Given this list of marker genes Rgcc, Myo1c, Mcub, Rapgef4, Aopep, Cnga1, Tnfrsf9, Dapl1, Nrp1, Swap70, Mxd1, Mbnl3, St3gal6, Gpr15, Ston1, Tmie, Il2rb, Gadd45b, Il1r2, Atp8b4, Foxp3, Cd79b, Adh1, Sh3bgrl2, Epas1, Map3k8, Plagl1, Stx11, Sema4a, Slc22a15, Neb, Il2ra, Capg, Soat1, Tnfrsf1b, Acsbg1, Ctla4, Cd81, Tanc1, 2900026A02Rik, Ggt5, Nfil3, Lclat1, Bach2, Itgae, Itih5, Rflnb, Ikzf2, Fah, Il1rl1, Rilpl2, Gsto1, Enc1, Penk, Cd83 (CD83 antigen), Tnfrsf18, Chd7, Pdk1, Frmd4b, Arhgap29, Nol4l, Ppm1l, Afp, Anxa4 (NCBI Gene Id 269772), Als2cl, Hopx, Pmaip1, Prkar1b, Vav2, Pxylp1, Apol9b, Alcam, Gpr83, Ramp3, Osbpl3, Il1rl2, Themis, Gpld1, Etfbkmt, Gbp4, Prc1, Tnfrsf4, Sema4f, Niban1, Mmd, Hspa1b, Lypd6b, Cttn, Twsg1, Myo10, Tiam1, Capn3, Pim1, Fasl, Gprc5b, Slc16a5, Ncf1, Syt11, Ttc7b, Rragd, Cdkn2c, A630001O12Rik, here is a description of the gene set: Regulatory CD4+ T cells (Tr cells), the development of which is critically dependent on X-linked transcription factor Foxp3 (forkhead box P3), prevent self-destructive immune responses. Despite its important role, molecular and functional features conferred by Foxp3 to Tr precursor cells remain unknown. It has been suggested that Foxp3 expression is required for both survival of Tr precursors as well as their inability to produce interleukin (IL)-2 and independently proliferate after T-cell-receptor engagement, raising the possibility that such 'anergy' and Tr suppressive capacity are intimately linked. Here we show, by dissociating Foxp3-dependent features from those induced by the signals preceding and promoting its expression in mice, that the latter signals include several functional and transcriptional hallmarks of Tr cells. Although its function is required for Tr cell suppressor activity, Foxp3 to a large extent amplifies and fixes pre-established molecular features of Tr cells, including anergy and dependence on paracrine IL-2. Furthermore, Foxp3 solidifies Tr cell lineage stability through modification of cell surface and signalling molecules, resulting in adaptation to the signals required to induce and maintain Tr cells. This adaptation includes Foxp3-dependent repression of cyclic nucleotide phosphodiesterase 3B, affecting genes responsible for Tr cell homeostasis. Cluster P4 of genes with similar expression profiles in peripheral T lymphocytes after FOXP3 loss of function (LOF). species: Mus musculus Mouse Gene Set: GAVIN_FOXP3_TARGETS_CLUSTER_P4 from publication Gavin MA, Rasmussen JP, Fontenot JD, Vasta V, Manganiello VC, Beavo JA, Rudensky AY (PMID 17220874)